The following is a description of a gene set: Activated ERBB2 heterodimers regulate cell motility through association with MEMO1. MEMO1 retains activated RHOA GTPase and its associated protein DIAPH1 at the plasma membrane, thus linking ERBB2 activation with the microtubule and actin dynamics downstream of the RHOA:GTP:DIAPH1 complex. part of: Signaling by ERBB2 Reactome Pathway: ERBB2 Regulates Cell Motility species: Homo sapiens, and this is the list of marker genes: ERBB4, NRG3, NRG4, EGFR, ERBB3, NRG2, ERBB2, EREG, RHOA, EGF, BTC, HBEGF, NRG1, MEMO1, DIAPH1